Given this list of marker genes Stx11, Syt13, Syt7, Vamp1, Snap47, Prrt2, Syt11, Syt8, Cplx2, Snap23, Syt5, Stxbp1, Syngr2, Cplx1, Snap29, Rph3a, Syt4, Doc2b (double C2, beta), Stx2, Doc2g (NCBI Gene Id 60425), Syt9, Snap25, Stx1a, Syt2, Rab3a (NCBI Gene Id 19339), Rims1 (NCBI Gene Id 77473), Erc2, Doc2a, Rph3al, Erc1, Syt1, Grik5, Ap3d1 (NCBI Gene Id 11776), Syngr1, Stx19, Stx1b, Rimbp2, Cplx3, Rims2, Cplx4, Cacna1b, Snapin, Tor1a, here is a description of the gene set: A process that is carried out at the cellular level which results in the assembly, arrangement of constituent parts, or disassembly of the membrane surrounding a synaptic vesicle. Mouse Gene Set: GOBP_SYNAPTIC_VESICLE_MEMBRANE_ORGANIZATION studied in species Mus musculus